The following is a description of a gene set: part of: Mitotic Prophase studied in species Mus musculus Reactome Pathway: Golgi Cisternae Pericentriolar Stack Reorganization electronically inferred by orthology from the curated human pathway This event has been computationally inferred from an event that has been demonstrated in another species.<p>The inference is based on the homology mapping from PANTHER. Briefly, reactions for which all involved PhysicalEntities (in input, output and catalyst) have a mapped orthologue/paralogue (for complexes at least 75% of components must have a mapping) are inferred to the other species., and this is the list of marker genes: Rab1a, Rab1b, Mapk3, Plk1, Blzf1, Golga2, Gorasp1